Given this list of marker genes PPARGC1B, RCAN2, PLPP3, SOX5, PAPPA, SMURF2, DENND1B, MFAP3L, UNKL, KIF16B, CDK6, GRK3, RTN4, LMAN1, MYCL, DCLK1, KIF13A, SALL3, CDK5RAP1, TFPI2, UBN2, CDS2, ADORA2B, VPS25, KIF5A, ELOVL7, RFX3, PTPN4, MTMR10, UHMK1, DESI1, IPO7, JAZF1, UFC1, ZFHX4, TNPO1, XPO4, CCNE2, PTPN3, BCL2, GTF2H1, CEP350, SREK1 (splicing regulatory glutamic acid and lysine rich protein 1), FRY, TPCN2, HECTD1, CNOT6L, FAM171A1, EPHB2 (EPH receptor B2), GOLIM4, KANK1, PIK3R1, GAL3ST3, KCNJ2, PNRC2, ZNF236, LPIN2, RNF111, CDC27, ZNF827, TBL1XR1, MPZL1, AKAP12, TIGAR, BTRC, CBX5, PIK3C2A, MEX3C, MGAT4A, EIF5B, FAM135A, AGO2, OCRL, PI4K2B, INSR, SESTD1, BIN1, IL17RD, CRYBG1, CDK8, LPAR3, FNDC3A, RASGEF1B, AKT3, COL7A1, TFG, MOV10, LYPLAL1, HSPA8, ASH1L, PACRG, AHCYL1, NUP160, MAP3K7, G2E3, TMCC1, TRIM36, LRP10, SETD5, HSPG2, DNAJA2 (NCBI Gene Id 9237), MTAP, DSE, RNF144B, WEE1, RCE1, BTF3, SYDE2, ZNRF3, VEGFA, DLG3, N4BP1, SDF2, ABCF3, ITGB8, CYP26B1 (cytochrome P450 family 26 subfamily B member 1), CREBRF, CPEB2, ZNF697, CAMSAP2, NKD1, FGF2, KLHL2, DIPK1A, ANKS1A, KCNQ5, E2F7, DCAF8, HOXD1, ARMH4, ADRA1A, VPS11, KIF21A, SLC11A2, NAA15, PDE4A, IGF1R, ANLN, G3BP2, CCNE1, TBC1D8B, RAF1, ACACB, DCC, KIF3B, P2RY12 (NCBI Gene Id 65213), C2orf72, NXPH1, GAREM1, PARD6B, PAM, NECAP1, GABARAPL1, KIF5B, TMEM100, FBXO33, TNRC6C, TMEM245, NECTIN3, TEPSIN, SMURF1, CNNM3, PRR3, FOXK1, GNG2, FCHSD2, RBM47 (RNA binding motif protein 47), NFE2L1, DHX33, CCND2, FHIP1A, ERI2, MACF1, RICTOR, RECK, ELOVL5, PTCD3, SEL1L, WDR43, ZNF367, DNAJC16, TSC22D2, MAP2K1, PAFAH1B1, CASR, DKC1, OMG, SALL1, PDAP1, PER1, HERPUD2, PIF1, CREBL2, DCAF17, GABRA1, GRM7, TIMM10B, KIF1C, ALK, NAA30, FGF7, FBXW7, UBE4B (NCBI Gene Id 10277), KPNA3, GLCE, CMC4, SRPRA, SCRN1, AKAP6, ELL2, ACVR2A, PURG, PRR11, WSB1, TTC33, FKBP1B, PURA, ANOS1, LHX1, MAP7D2, CDCA4 (cell division cycle associated 4), CCND3, GAN, INSYN2A, NEXMIF, CCNYL1, NR2E1, TXLNA, FOSL1, FAM168A, SFXN1, ZNF622, ASAP1, STOX2, DLC1, DVL1 (NCBI Gene Id 348497), CMPK1, PLEKHA3, SEC24A, LATS2, LUZP1, MTOR, FAM199X, CKAP2L, BAG3, PIP5K1B, USP25 (NCBI Gene Id 29963), here is a description of the gene set: Human Gene Set: MIR646 from publication Chen Y, Wang X (PMID 31504780) Genes predicted to be targets of miRBase v22 microRNA hsa-miR-646 in miRDB v6.0 with MirTarget v4 prediction scores > 80 (high confidence targets). studied in species Homo sapiens